Given this list of marker genes KDM4D, KMT5C, RIF1, MAD2L2, FH, PARP3, SHLD1, KMT5B, CYREN, TOP2B, SHLD2, SHLD3, WRAP53, PRKDC, PNKP, SMCHD1, SETMAR, here is a description of the gene set: Any process that activates or increases the frequency, rate or extent of double-strand break repair via nonhomologous end joining. species: Homo sapiens Human Gene Set: GOBP_POSITIVE_REGULATION_OF_DOUBLE_STRAND_BREAK_REPAIR_VIA_NONHOMOLOGOUS_END_JOINING